The following is a description of a gene set: mouse primary BMDCs were stimulated with tlr ligands and gene expression changes were profiled on Affymetrix arrays Genes down-regulated in comparison of dendritic cells (DC) stimulated with LPS (TLR4 agonist) at 0.5 h versus those stimulated at 12 h. Human Gene Set: GSE17721_0.5H_VS_12H_LPS_BMDC_DN species: Homo sapiens from publication Amit I, Garber M, Chevrier N, Leite AP, Donner Y, Eisenhaure T, Guttman M, Grenier JK, Li W, Zuk O, Schubert LA, Birditt B, Shay T, Goren A, Zhang X, Smith Z, Deering R, McDonald RC, Cabili M, Bernstein BE, Rinn JL, Meissner A, Root DE, Hacohen N, Regev A (PMID 19729616), and this is the list of marker genes: DNER, ZNF841, ANXA5, GSR, VDAC3 (NCBI Gene Id 7419), PMVK, ZBTB37, DMKN, VPREB3, N4BP1, NINJ1, WIZ, M1AP, PTX3, CCL13, CYP27B1, ME1, DUSP26, MFSD1, SELENOW, NCOA3, COL22A1, CX3CL1, TTLL3, GALR3, IMMP1L, MAPK6, UBXN8, PDE6D, GCH1, CITED2, MED28, PIKFYVE, AOPEP, PTPRO, KREMEN1, AMELX, CD47, SLC28A2, NFKB1, CD81, CTSK, MAFG, UPP1, CRK, RBM5, UGP2, CYBB, OAS2, BCAM, OLR1, TIA1, IGBP1, PDLIM4, TCF4, SLC6A4, PENK, SPATA4, ZNF426, CFLAR, FNTB, NAMPT, UBE2S, PEF1, STARD3NL, CPD, DCAKD, DTNB, HELZ2, RASA2, ATAD1, ATM, ITGA4, PCNX1, C1orf52, HSD17B13, GCC2, RPS6KA2, TMA16, AHCYL1, JAK2, ATP2C1, ANXA1, PTPN11 (protein tyrosine phosphatase non-receptor type 11), CEP350, SYNPO2, PRKD1, TBPL1, CGGBP1, MYCBP, LAPTM4A, RARG, B2M, POU2F2, TSPAN33, POLR2C, ARHGAP17, HNRNPH3, ZNF526, GFRA4, RPE, CCNT2, YKT6 (NCBI Gene Id 63236), IFNAR2, USP3 (NCBI Gene Id 9960), TMEM175, ATF3, EXTL1, SQSTM1, SAMSN1, PXMP2, ACAA1, KHDC4, GRINA, NIPSNAP3A, RBM43, STARD3, IREB2, IRGM, SPTLC2, ZNRF1, CAB39L, ABR, NDRG2, CPSF2, SEPTIN7, PDIA5 (NCBI Gene Id 10954), CCL5, SMC5, GDI1, NET1, TMED7, NUDT9, CRYM, IER5, SOX12 (NCBI Gene Id 6666), GDE1, MMP14, TSPYL1, RNF114, PPP1R1B, CREBZF, NECTIN2 (nectin cell adhesion molecule 2), TXLNG, DSPP, TRIM25, GRK2, P2RY14, EEF1E1, PMPCB, MITD1, KATNA1, FBXO11, TBC1D13, CXCL9, C1QL3, VAMP8, SEC23A, CD200, AMMECR1, GTF2E2, HSPB8, ATP6V1E1, WASHC3, ARID5B, ALKBH4, CRYGS, GBP2 (guanylate binding protein 2), SCN8A, MOB4, SLFN13, PRPF38A, METTL6, MDFIC, NR2C1, ASB6, DUSP16 (dual specificity phosphatase 16), CTTN, MTDH, BNIP2, SEC24D, G3BP2, ENPP3, FST, ILF3, IL15RA, MMP2, STARD5, GAK, PARD6A, DNAJC1, RAB10, ARG2, KATNBL1, SERPINE1, HOOK2, IFT81, CCNT1, TMEM30A